The following is a description of a gene set: part of: Complement cascade species: Homo sapiens Reactome Pathway: Regulation of Complement cascade Two inherent features of complement activation make its regulation very important: <br>1. There is an inherent positive feedback loop because the product of C3 activation forms part of an enzyme that causes more C3 activation.<br>2. There is continuous low-level activation of the alternative pathway (see Spontaneous hydrolysis of C3 thioester).<br><br>Complement cascade activation is regulated by a family of related proteins termed the regulators of complement activation (RCA). These are expressed on healthy host cells. Most pathogens do not express RCA proteins on their surface, but many have found ways to evade the complement system by stably binding the RCA that circulates in human plasma; trapping RCA is by far the most widely employed strategy for avoiding the complement response. RCA recruitment is common in bacteria such as E. coli and streptococci (Kraiczy & Wurzner 2006) and has also been described for viruses, fungi and parasites. RCA deposition and the complement system also have an important role in tissue homeostasis, clearing dead cells and debris, and preventing damage from oxidative stress.<br><br>RCA proteins control complement activation in two different ways; by promoting the irreversible dissociation (decay acceleration) of complement convertases and by acting as cofactors for Complement factor I (CFI)-mediated cleavage of C3b and C4b.<br>Decay accelerating factor (DAF, CD55), Complement factor H (FH), Membrane Cofactor Protein (MCP) and Complement receptor 1 (CR1) are composed of arrays of tandem globular domains termed CCPs (complement control protein repeats) or SCRs (short consensus repeats). CR1, MCP and FH are cofactors for the CFI-mediated cleavage of C3b, generating iC3b. CR1 and MCP are also cofactors for C4b cleavage.<br> C4BP is an additional cofactor for the CFI-mediated cleavage of C4b., and this is the list of marker genes: IGLV3-25, IGKV5-2 (NCBI Gene Id 28907), C8G, CLU, CPN2, CPN1, IGLV2-18, IGHV4-59, C1QA, CFHR4, IGHV, IGLV1-36, C7, IGHG2, IGHG1, C1QB, IGLV5-45, C1R, F2, C4B, C4A, IGHV3-53, C5AR1, IGLV7-43, IGKV2D-30, IGLV2-23, IGKV1D-12, IGLC7, IGLV4-69, IGLV3-19, C4BPA, IGLV2-33, CFH, IGKV1D-16, IGKV4-1, IGLV1-44, IGHG3, CFP, IGKV1D-39, IGKV1-33, CFHR5, IGHV2-70, CFHR2, IGLV2-8, IGLV8-61, IGLV1-40, CD19, IGLV10-54, CD59, IGHV3-33 (immunoglobulin heavy variable 3-33), C3, IGKV1-17, IGKV1D-33, IGHV3-30, IGHV3-13, CFB, C6, IGLV2-14, SERPING1, IGKV2-28, IGLV6-57, C3AR1, CFHR3, IGLV1-47, C1QC, IGKV1-16, IGKV3-15, IGHV4-39, IGKV3-11, CR2, IGLV3-27, IGKV1-12, IGLV3-12, IGHV3-23, CR1, C5, IGLV5-37, IGLV3-21, CD55, C5AR2, IGLC1, IGHV1-69, C8B, IGKV1-39, IGLV, C2, IGLV1-51, VTN, IGKV2-29, IGKC (NCBI Gene Id 3514), IGLC3, IGKV2D-40 (immunoglobulin kappa variable 2D-40), PROS1, CD81, IGLV3-1, IGHV3-11, IGLC6, IGKV3-20, IGLV3-22, IGKV2-30, C8A, IGHV2-5, CFHR1, IGLV7-46 (NCBI Gene Id 28775), IGHV3-48, IGHV3-9, IGLV3-16, C1S, IGHV3-7, IGHV1-2, IGLV4-3, CPB2, IGLV11-55, IGKV3D-20, IGLV4-60, C9, IGHV7-81, C4BPB, IGLC2, IGHG4, CD46, ELANE, CFI, IGKV2D-28, IGKV1-5, IGLV2-11, IGHV4-34, IGHV1-46